The following is a description of a gene set: species: Homo sapiens CYP11B1-CYP11B2 fusion to ACTH-cortisol signaling pathway. Pathway ID: N00298. Pathway type: Variant. Pathway class: nt06310 CRH-ACTH-cortisol signaling. Pathway Definition from KEGG: ACTH -> (MC2R+MRAP) -> GNAS -> ADCY -> cAMP -> PKA -> (NR5A1,NR4A1,SP1,PBX1,CREB) => CYP11B2* -> Aldosterone Human Gene Set: KEGG_MEDICUS_VARIANT_CYP11B1_CYP11B2_FUSION_TO_ACTH_CORTISOL_SIGNALING_PATHWAY, and this is the list of marker genes: ATF6B, ADCY9, CREB3, ATF4, ADCY1, CREB3L4, CYP11B2, ADCY6, CREB3L2 (cAMP responsive element binding protein 3 like 2), ADCY7, CREB3L1, CREB5, POMC, ADCY8, MRAP, MC2R, GNAS, PRKACA, PRKACB, ADCY3, PBX1, ADCY4, PRKACG, ADCY2, NR4A1, CREB3L3, NR5A1, ATF2, CREB1, SP1, ADCY5